The following is a description of a gene set: Human Gene Set: GOBP_NEGATIVE_REGULATION_OF_CELL_SUBSTRATE_JUNCTION_ORGANIZATION Any process that stops, prevents or reduces the frequency, rate or extent of cell-substrate junction organization. species: Homo sapiens, and this is the list of marker genes: ITGB1BP1, FAM107A, PHLDB2, CORO1C, DMTN, ACVRL1, SRC, DLC1, RCC2, CLASP2, THBS1, PTEN, MMP14, DUSP22, ARHGAP6, APOD